Given this list of marker genes DLK1, MEG3, MYH3, NALCN, RTL1, here is a description of the gene set: Chin with H-shaped crease species: Homo sapiens Human Gene Set: HP_CHIN_WITH_H_SHAPED_CREASE H-shaped crease in the fat pad of the chin.